Given this list of marker genes GCLC, POR, GATA1, GCLM, EFNA5, EDN1, SCX, INHBA, EPHA8, NOTCH1, FSHR, EDNRA, here is a description of the gene set: Any process that results in a change in state or activity of a cell (in terms of movement, secretion, enzyme production, gene expression, etc.) as a result of a follicle-stimulating hormone stimulus. Human Gene Set: GOBP_CELLULAR_RESPONSE_TO_FOLLICLE_STIMULATING_HORMONE_STIMULUS studied in species Homo sapiens